The following is a description of a gene set: Human Gene Set: HP_NEUROENDOCRINE_NEOPLASM A tumor that originates from a neuroendocrine cell. studied in species Homo sapiens Neuroendocrine neoplasm, and this is the list of marker genes: CCND1, PRKAR1A, TMEM127, SDHC (NCBI Gene Id 6391), DLST (dihydrolipoamide S-succinyltransferase), DNMT3A, SDHAF2, ATRX, CDKN1B, CDKN1A, IFNG, LMNA, SDHD, MDH2, VHL, APC, EPAS1, RET, KCNJ11, KIF1B, CDKN2B, FH, MAX, MAFA, GCGR, SDHB, GNAS, KDM1A, ARMC5, YY1, NF1, HRAS, TSC1, TSC2, SDHA (NCBI Gene Id 6389), CDKN2C, MEN1, SLC25A11